The following is a description of a gene set: from publication Tabula Muris Consortium (PMID 32669714) species: Mus musculus Mouse Gene Set: TABULA_MURIS_SENIS_MESENTERIC_ADIPOSE_TISSUE_CD4_POSITIVE_ALPHA_BETA_T_CELL_AGEING, and this is the list of marker genes: Tmsb10, Srsf2, Nsd3, Tmem160, Jund, Timeless, Lamp1, Sparc, Tle5, Nrp1, Mier1, Gstm1, Dpysl2, Lgmn, Eif1, Ier2, 9930111J21Rik1, Arglu1 (NCBI Gene Id 319920), Arrb2, Cebpb, Lyz2, Ctsd, Emc10, Apbb1ip, Rbm26 (RNA binding motif protein 26), Aup1, Gnb1, Senp6, Cst3, H2-Q6 (histocompatibility 2, Q region locus 6), Wbp2, C1qa, Snf8, Cdc37, Snrnp70, Nudt3, Arhgdia, Junb, P2ry12, Klf13, Crip2, Pi16, B2m, Dusp5, Nfkbia, Smad7, Vps37b, Kdm6b, Gpr132, Dcn, Ltb, Aamp, Zfc3h1, Marf1, Cotl1, Prr13, Cfl1, Hexb, Mgp, Ppp1r35, Grn, Gsn, Rpl13a, Ctsb, Sod1, Drap1, S100a8